The following is a description of a gene set: from publication Nakaya HI, Wrammert J, Lee EK, Racioppi L, Marie-Kunze S, Haining WN, Means AR, Kasturi SP, Khan N, Li GM, McCausland M, Kanchan V, Kokko KE, Li S, Elbein R, Mehta AK, Aderem A, Subbarao K, Ahmed R, Pulendran B (PMID 21743478) Systems vaccinology has emerged as an interdisciplinary field that combines systems wide measurements and network and predictive modeling applied to vaccinology. Here we used the systems vaccinology approach to study the molecular mechanisms underlying th Genes down-regulated in comparison of B cells from TIV influenza vaccinee pre-vaccination versus those at day 7 post-vaccination. Human Gene Set: GSE29618_PRE_VS_DAY7_POST_TIV_FLU_VACCINE_BCELL_DN studied in species Homo sapiens, and this is the list of marker genes: MPC2, SH3BGR, H1-2, MYH3, RPRD2, PDE5A, GYG1, C10orf88, CES2, ATP6V0E2, EVL, SLFN12 (schlafen family member 12), CPA2, CANX, CCNB1, MX2, BCAR3, COPZ1, SERPINI2, COBLL1, RPL6, ENY2, CEACAM1 (CEA cell adhesion molecule 1), CDC42SE1, HNRNPA0, PLK4, IGLL3P, IPO9, VPS52, SF3B3, PARP11, WASHC3, HEBP2, PKIG, MYOF, UQCRQ, IMP4, POLH, VCX2, MTMR7, CIAO2B, TXNL1, IRF3, ITGB1BP1, TASOR, ZNF207, ZNF197, MAPK14, KCTD9, CERNA1 (NCBI Gene Id 100129973), ANXA6, TBC1D9B, MBNL2, FBXO22, IGKV1D-13, MNAT1, FUBP3, ETFDH, TMEM39B, PNOC, RPL22, CDR2, GFOD1, ZDHHC11, DERL2, NET1, BLOC1S1, PTGS2, LRRC1, RRS1, MTRF1L, TACC3, STN1, CDKL2, TRAM2 (NCBI Gene Id 9697), TAF1D, NUP58, RPL7, CAMK1D, SCFD1, ZNF267, TENT5A, MICAL3, FOXN2, BTF3P12, PRKCD, RBBP6, RYBP, MBD1, TXNL4A, ZNF135, SLC16A3, MRPL41 (mitochondrial ribosomal protein L41), ZNF83, EHBP1L1, PPP2R3C, CTAGE1, JADE1, SPATA1, IKBKB, LSM3, PITPNB, NUDT3, DNAH7, DCAF8, SP2, PAK1IP1, ADRM1, GINS2, COX6A1, UQCR10, CSNK1G3, MAST2, TRIM5, FIBP, PDE7B, AREL1, TMBIM4, GGA1, PFDN1, CCNG1, ZNF205, MAP3K2 (mitogen-activated protein kinase kinase kinase 2), MRPS2, MCRS1, MGST3, WWOX, H2BC4, OSGIN2, ANKHD1, ELP5, PFDN4, TOR1B, ZNF133, TTF1, LGALSL, RPN2, BNIP1, KLHL12, SMUG1 (single-strand-selective monofunctional uracil-DNA glycosylase 1), MIF, CFL1, HSPA1L, PTTG1, PAFAH1B3, ASCC2, MUC16, ARFIP2, PIK3C3, ZNF408, ALDH7A1, IFT81, PPP2CA (protein phosphatase 2 catalytic subunit alpha), RCN2, SAP30L-AS1, DNM1L, HECTD3, DNAI7, SEC13, RLF, AMPD3, HOXA1, UCHL5, ACTR5, TBC1D10B, BICRA, MIA2, TRAF1, POLD4, KLHL5, CCNB1IP1, ZNF32, YARS1, GGPS1, INHBC, NARS1, DNAJC10, C11orf24, RPL23AP53, ATF2, FUCA1, SRSF3, ARHGAP35, KDELR1, R3HDM1, ZNF767P (NCBI Gene Id 79970), LRRTM2, ARHGEF5, CYFIP2, CILK1, FKBP14, GATD3, IKBKG, H2AC18, DNAJB4, NINL (NCBI Gene Id 80250)